Given this list of marker genes SLC6A19, here is a description of the gene set: species: Homo sapiens Reactome Pathway: Defective transport of neurotransmitters by SLC6A19 causes Hartnup disorder (HND) SLC6A19 encodes the sodium-dependent neutral amino acid transporter B(0)AT1 and mediates the uptake of neutral amino acids across the plasma membrane accompanied by uptake of a sodium ion. The protein is abundantly expressed in the small intestine and kidney (Broer & Gether 2012, Schweikhard & Ziegler 2012). Defects in SLC6A19 can cause Hartnup disorder (HND; MIM:234500), an autosomal recessive abnormality of renal and gastrointestinal neutral amino acid transport characterised by increased urinary and intestinal excretion of neutral amino acids. Symptoms include transient manifestations of rashes, cerebellar ataxia and psychotic behaviour. Some mutations in SLC6A19 are thought to contribute to the phenotypes iminoglycinuria (IG; MIM:242600) and hyperglycinuria (HG; MIM:138500). part of: SLC transporter disorders